The following is a description of a gene set: Human Gene Set: GSE22886_NAIVE_CD4_TCELL_VS_12H_ACT_TH1_UP Immune cell-specific expression is one indication of the importance of a gene's role in the immune response. In order to identify such patterns, we set out to broadly profile gene expression in a variety of immune cells. Genes up-regulated in comparison of naive CD4 T cells versus stimulated CD4 Th1 cells at 12 h. species: Homo sapiens from publication Abbas AR, Baldwin D, Ma Y, Ouyang W, Gurney A, Martin F, Fong S, van Lookeren Campagne M, Godowski P, Williams PM, Chan AC, Clark HF (PMID 15789058), and this is the list of marker genes: GARRE1, TSPYL1, SMPD1, RPL29, CTNNBIP1, SP140L, CTC1, CCNL1, BCL11B, KLF3, R3HDM2, RBMS1, DENND2A, USP25, LTBP3, SH3YL1, HOOK2, GLS2, CCSER2, CEP164, NLRP1, PEX1, IL11RA, ZFP36L2, PFDN5, RYK, ADA2, SAMHD1, SKAP1, TJP3, CD248, CLUHP3, MYO15B, NMUR1, PDLIM2, KCND1, SPSB3, LIPA (NCBI Gene Id 3988), EEF2 (eukaryotic translation elongation factor 2), CAMLG, TP53TG1, PHKA2, ZBTB25, SHOC2, MYH3, SERPING1 (serpin family G member 1), PLCL2, FXYD5, DGKZ, BNIP3L, CHKB, TRIM44, CLK4, ANKEF1, CDK18, FLI1, RASGRP2, GPSM3, RPS29, ZNF83, STAT6, MN1, MARCHF8, TRAM2, PLCH2, IL7R, AKT2, AP4S1, RSAD1, ARL2BP, BLTP1, EIF4B, EIF4EBP2, RPS20, AP1G2, DYRK1A, ARFGAP2, CMPK1, TLE5, PTGER1, CIC, FLOT2, RPL8, ARHGAP33, SH2B1, ADD3, ANKZF1, LRCH4, UBE2H, SF1, FOXB1, CBX7, RAB40C, PCOLCE2, VAT1, APBB3, MRNIP (MRN complex interacting protein), TENT4A, BTG1, KCTD7, LSM14A, ERP29, POU5F1P3, CEP68, RPS9 (ribosomal protein S9), ATXN7, ZNF395, ATXN7L3B, SVIL, WAC, RUNX1T1, CACTIN, SETX, FNBP1, MPO, INPP4A, CLEC11A, HBP1, ISYNA1, FAAH, STMN3, ARHGEF18, ATP1A1, NKTR, CDC37L1, ECHDC2, ASTN2, SP110, HPX (hemopexin), RAB25, TRAPPC6A, TMEM123, ZNF671, CEP350, CAPN3, BICRAL, MEF2A, BIN2, WWP1, TULP4, TRIM22, PHC1, LZTFL1, VPS8, HERC1, BBS1, CLK1, OGA, WNT7A, LONP2, TXNIP, SST, DCAF11, ARHGEF1, GPR18, CARS2, CFAP410, MAP3K1, DNAJB1, ABCC5, PBXIP1, DNAL4 (dynein axonemal light chain 4), STARD3, AQP3, LSM14B, HLA-DOB, SIDT1 (NCBI Gene Id 54847), STIM1, COQ8A, MYCBP2, TSPAN32, CLN3, RAB5B, DCUN1D2, VPS13D, TSC2, CTSO, PRMT2, GRIA3, HYI, ZXDC, CD44, SERPINF2, ZNF292, IQSEC1, ATP8A1, CREBL2, VPS13C, DENND5A, PCIF1, SUN1, RAB5C, USP21, SARAF, MALT1, ARRB1, ZFC3H1, PBX1, CABIN1